The following is a description of a gene set: species: Homo sapiens Catalysis of the reaction: estradiol-17-beta + NAD(P)+ = estrone + NAD(P)H + H+. The activity can use NAD+ or NADP+ as the acceptor. Human Gene Set: GOMF_ESTRADIOL_17_BETA_DEHYDROGENASE_NAD_P_PLUS_ACTIVITY, and this is the list of marker genes: HSD17B2, AKR1B15, HSD17B8, AKR1C2, HSD17B14, RDH8, HSD17B6, HSD17B10, HSD17B13, AKR1C4, HSD17B1, DHRS11, HSD17B4, AKR1C3, AKR1C1, HSD17B7, HSD17B12, HSD17B11, HSD17B3